The following is a description of a gene set: Mouse Gene Set: MIR_5130 from publication Chen Y, Wang X (PMID 31504780) studied in species Mus musculus Genes predicted to be targets of miRBase v22 microRNA mmu_miR_5130 in miRDB v6.0 with MirTarget v4 prediction scores > 80 (high confidence targets)., and this is the list of marker genes: Sybu (syntabulin (syntaxin-interacting)), Tbc1d25, Tln1, Osbpl7, Adam23 (a disintegrin and metallopeptidase domain 23)